Given this list of marker genes COL4A6, COL4A1, COL4A5, DDR1, SYK, COL4A2, UBASH3B, GP6, DDR2, COL1A1, TSPAN9, COL4A3, here is a description of the gene set: Human Gene Set: GOBP_COLLAGEN_ACTIVATED_TYROSINE_KINASE_RECEPTOR_SIGNALING_PATHWAY The series of molecular signals initiated by collagen binding to its receptor on the surface of a target cell where the receptor possesses tyrosine kinase activity, and ending with the regulation of a downstream cellular process, e.g. transcription. studied in species Homo sapiens